The following is a description of a gene set: The presence of inflammation of the epididymis. Epididymitis Human Gene Set: HP_EPIDIDYMITIS studied in species Homo sapiens, and this is the list of marker genes: ERAP1, HLA-B, KLRC4, IL12A-AS1, UNG, C4A, TLR4, PSMB8, IL10, CCR1, IGKC, IGHG2, MEFV, LYN, UBAC2 (NCBI Gene Id 94902), FAS, STAT4, IL12A, IFNGR1, BTK, IL23R